Given this list of marker genes ASIC4, KCNH7, HCN4, BEST2, TRPM2, CNGA2, KCNK1, KCNMB2, GRIA3, SCNN1B, P2RX3, KCNMA1, KCNT2, MCOLN2, KCNH2, MCOLN1, TRPM4, KCNN1, KCNN3, CNGB3, CHRNA7, RYR2 (NCBI Gene Id 6262), CNGA4, HTR3C, GRIK3, HTR3D, TRPA1, CHRNE, KCNJ10, CHRFAM7A, SHROOM2 (shroom family member 2), CHRNA1, CHRNB2, TPCN2, KCNJ9, KCNN4, KCNJ15, KCNN2, CHRNG, AQP1, SCNN1G, GRIN2A, CNGA1, ZACN, KCNT1, KCNJ13, KCNH6, MCOLN3, PKD2, KCNMB1, HTR3E, GRIK2, ITPR2, CHRNA2, PKD1L3, TRPC3, KCNU1, ANO6, CHRNB3, ASIC1, CNGB1, GRIN3B, GRIN3A, RYR3, ABCC8, CHRNA9, P2RX4, HCN2, CHRNB1, ASIC3, HCN1, CHRND, CCDC51, ASIC2, KCNE2, CCT8L2, P2RX7, CALHM1, TMEM63A, CATSPER4, KCNJ4, SCNN1D, CHRNA3, PKD2L1, KCNJ8, CATSPER1 (cation channel sperm associated 1), KCNJ2, P2RX1, ITPR1, KCNMB4, KCNA10, CHRNB4, KCNJ1, KCNJ5, GRIK1, TRPM5, KCNJ6, RYR1, CHRNA10, CHRNA6, GRIN2D, P2RX5, TRPV1, CNGA3, KCNH3, CHRNA5, CATSPER2, GRIK4, TRPM8, GRIN2B, ITPR3, CAV1, ANO10, KCNJ12, TMEM63B, CHRNA4, KCNJ3, KCNJ11, KCNK18, HTR3B, SCNN1A (sodium channel epithelial 1 subunit alpha), KCNMB3, GRIA1, TMEM63C, KCNK6, GRIK5, KCNJ16 (NCBI Gene Id 3773), KCNJ14, KCNJ18, P2RX2, GRIN1, GRIA2, BNIP1, ASIC5, ABCC9, ANO1, P2RX6, TPCN1, HTR3A, here is a description of the gene set: studied in species Homo sapiens Human Gene Set: GOMF_LIGAND_GATED_MONOATOMIC_CATION_CHANNEL_ACTIVITY Enables the transmembrane transfer of an inorganic cation by a channel that opens when a specific ligand has been bound by the channel complex or one of its constituent parts.